The following is a description of a gene set: from publication van den Biggelaar AH, Pomat W, Bosco A, Phuanukoonnon S, Devitt CJ, Nadal-Sims MA, Siba PM, Richmond PC, Lehmann D, Holt PG (PMID 21645573) Genes down-regulated in peripheral blood mononuclear cell stimulated vs unstimulated in infants (9m) after exposure to Prevnar (USA), time point 9M and 8M (identical response signature) Concerns about the risk of inducing immune deviation-associated neonatal tolerance as described in mice have restricted the widespread adoption of neonatal vaccination. The aim of this study was to demonstrate the immunological feasibility of neonatal pneumococcal conjugate vaccination (PCV) which could potentially protect high-risk infants in resource poor countries against severe pneumococcal disease and mortality in the early critical period of life. Papua New Guinean infants were randomized to be vaccinated with the 7-valent PCV (7vPCV) at birth, 1 and 2 months (neonatal group, n=104) or at 1, 2 and 3 months of age (infant group, n=105), or to not receive 7vPCV at all (control group, n=109). Analysis of vaccine responses at 3 and 9 months of age demonstrated persistently higher type-1 (IFN-gamma) and type-2 (IL-5 and IL-13) T-cell responses to the protein carrier CRM(197) and IgG antibody titres to 7vPCV serotypes in children vaccinated with 7vPCV according to either schedule as compared to unvaccinated children. In a comprehensive immuno-phenotypic analysis at 9 months of age, no differences in the quantity or quality of vaccine-specific T cell memory responses were found between neonatal vaccinations versus children given their first PCV dose at one month. Hospitalization rates in the first month of life did not differ between children vaccinated with PCV at birth or not. These findings demonstrate that neonatal 7vPCV vaccination is safe and not associated with immunological tolerance. Neonatal immunisation schedules should therefore be considered in high-risk areas where this may result in improved vaccine coverage and the earliest possible protection against pneumococcal disease and death. species: Homo sapiens Human Gene Set: VAN_DEN_BIGGELAAR_PBMC_PREVNAR_9MO_INFANT_STIMULATED_VS_UNSTIMULATED_9MO_DN, and this is the list of marker genes: FABP4, CD163, MS4A4A, MERTK, CD14